The following is a description of a gene set: Mouse Gene Set: GOMF_D_LOOP_DNA_BINDING species: Mus musculus Binding to a DNA D-loop. A D-loop is a three-stranded DNA structure formed by the invasion of a single DNA strand that base pairs with one strand of duplex DNA, while the rest of the double-stranded DNA does not unwind., and this is the list of marker genes: Rad51ap1 (RAD51 associated protein 1), Wrn (NCBI Gene Id 22427), Hmga1, Recql4, Pot1a, Pot1b, Blm